Given this list of marker genes PRKCG, GNG7, GNG2, GNB3, GNB1, GNG11, GNGT2, PLCB1, GNG10, PLCB3 (phospholipase C beta 3), PRKCB, GNB4, GNG13, GNGT1, GNG5, CCL5, GNG12, PRKCA, PLCB4, GNB2, GNG4, PLCB2, GNB5, CCR5, GNG3, GNG8, here is a description of the gene set: Pathway Definition from KEGG: CCL5 -> CCR5 -> GNB/G -> PLCB -> (Ca2+,DAG) -> PKC Human Gene Set: KEGG_MEDICUS_REFERENCE_CCR5_GNB_G_PLCB_G_PKC_SIGNALING_PATHWAY species: Homo sapiens CCR5-GNB/G-PLCB/G-PKC signaling pathway. Pathway ID: N00428. Pathway type: Reference. Pathway class: nt06167 Human cytomegalovirus (HCMV).